The following is a description of a gene set: Human Gene Set: HP_NARROW_VERTEBRAL_INTERPEDICULAR_DISTANCE A reduction of the distance between vertebral pedicles, which are the two short, thick processes, which project backward, one on either side, from the upper part of the vertebral body, at the junction of its posterior and lateral surfaces. species: Homo sapiens Narrow vertebral interpedicular distance, and this is the list of marker genes: KIF22, TONSL, RMRP, HNRNPR, NPR2, EXOC6B, LTBP3, SLC35D1, PDE4D, FGFR3, PRKAR1A, DDRGK1, GNPTAB, CHST3